The following is a description of a gene set: species: Mus musculus Mouse Gene Set: GOCC_ALVEOLAR_LAMELLAR_BODY A specialized secretory organelle found in type II pneumocytes and involved in the synthesis, secretion, and reutilization of pulmonary surfactant., and this is the list of marker genes: Napsa, Sftpc, Tmem63b, Ctsh, Sftpb, Abca3, Rab14, Lamp3, Lamp1, Rab7